The following is a description of a gene set: studied in species Homo sapiens Reactome Pathway: Defective Inhibition of DNA Recombination at Telomere Due to DAXX Mutations A small portion of tumors that are positive for alternative lengthening of telomeres (ALT) markers and negative for mutations in the ATRX gene harbor loss-of-function mutations in the DAXX gene, which encodes the ATRX binding partner DAXX. For review, please refer to Gocha et al. 2013, and Pickett and Reddel 2015. part of: Defective Inhibition of DNA Recombination at Telomere, and this is the list of marker genes: ATRX, DAXX